Given this list of marker genes Hprt1 (NCBI Gene Id 97612), Ada, Dck, Adal, Gmpr, Ampd3, Aprt, Adk, Ampd1, Dguok, Ampd2, Gmpr2, Pnp2, Pnp, here is a description of the gene set: species: Mus musculus Mouse Gene Set: REACTOME_PURINE_SALVAGE Purine salvage